Given this list of marker genes RBBP8, B4GALT7, PLK4, DNA2, COL3A1, ESCO2, POLR3A, CEP152, EP300, PCNT, ATRIP, NUP85, ATR, TRAIP, CENPE, ZNF407 (NCBI Gene Id 79610), HMX1, CREBBP, KMT2B, here is a description of the gene set: Human Gene Set: HP_ABSENT_EARLOBE Absent earlobe Absence of fleshy non-cartilaginous tissue inferior to the tragus and incisura. species: Homo sapiens